The following is a description of a gene set: Focal automatism seizure studied in species Homo sapiens A focal seizure characterized at onset by coordinated motor activity. This often resembles a voluntary movement and may consist of an inappropriate continuation of preictal motor activity. Human Gene Set: HP_FOCAL_AUTOMATISM_SEIZURE, and this is the list of marker genes: LAMC3, SCN2A, LGI1, SCN1A, ATP1A2, RELN, MICAL1, KCNQ3, KCNQ2, CACNA1A, PRRT2, SCN8A